The following is a description of a gene set: The series of molecular signals generated as a consequence of a component of the complement pathway binding to a complement receptor. Such components include both whole complement proteins and fragments of complement proteins generated through the activity of the complement pathway. Human Gene Set: GOBP_COMPLEMENT_RECEPTOR_MEDIATED_SIGNALING_PATHWAY studied in species Homo sapiens, and this is the list of marker genes: FPR3, C3AR1, ITGAM, CR2, GPR32, FPR1, FPR2, RGCC, C5AR2, GPR32P1, GPLD1, C3, CR1, AKT1, CMKLR1, C5AR1, GPR33